The following is a description of a gene set: Reactome Pathway: Pyrimidine salvage electronically inferred by orthology from the curated human pathway part of: Nucleotide salvage species: Mus musculus This event has been computationally inferred from an event that has been demonstrated in another species.<p>The inference is based on the homology mapping from PANTHER. Briefly, reactions for which all involved PhysicalEntities (in input, output and catalyst) have a mapped orthologue/paralogue (for complexes at least 75% of components must have a mapping) are inferred to the other species., and this is the list of marker genes: Cda, Uck1, Pudp, Upp1, Uckl1 (NCBI Gene Id 68556), Tymp, Dck, Tk1